Given this list of marker genes Tet3, Dnmt1 (DNA methyltransferase 1), Lrwd1, Tet1, Cxxc5, Cdx2, Mbd2, Cxxc4, Hoxb13, Mbd3, Zbtb21, Erh, Erhrt-ps, Wdr77, Uhrf1, Cdx1, Zcwpw1 (NCBI Gene Id 381678, zinc finger, CW type with PWWP domain 1), Prmt5, Mbd3l1, Zbtb33, Chtop, Prmt1, Lhx4, Mbd1, Mecp2, Mbd3l2, Zbtb4, Zbtb38, here is a description of the gene set: studied in species Mus musculus Binding to a methylated cytosine/guanine dinucleotide. Mouse Gene Set: GOMF_METHYL_CPG_BINDING